Given this list of marker genes Kdm1b, Dppa3, Dnmt3l, Zfp57, Zfp445, Meg3, here is a description of the gene set: Mouse Gene Set: GOBP_EPIGENETIC_PROGRAMING_OF_FEMALE_PRONUCLEUS studied in species Mus musculus The global programming of epigenetic modifications in the female pronucleus of the newly fertilized zygote. The maternal genome is protected from global DNA demethylation before the first division of the zygote, and instead undergoes passive, replication-dependent demethylation during early embryogenesis, arising from inhibition of the DNA maintenance methyltransferase Dnmt1.